The following is a description of a gene set: Any process that modulates the frequency, rate or extent of leukocyte proliferation. Mouse Gene Set: GOBP_REGULATION_OF_LEUKOCYTE_PROLIFERATION species: Mus musculus, and this is the list of marker genes: Il6, Il13, Cd40, Il12rb1, Sash3, Cd320, Nr5a2, Cd244a, H2-DMb1, Ido1, Cdkn2a, Il6st, Pawr, Wnt3a, Ighd, Prnp, Laptm5, Ephb2, Zc3h12d, Igfbp2, Vsig4, Cd209d, Mapk8ip1, Hes1, Csf2, Adk, Ikzf3, Tnfrsf21, Il1a, Rc3h1, Il23a, H2-DMb2, Mif, Cd24a, Tnfsf13, Stat6, Slc4a1, Ahr, Sos1, Bcl6, Cd38 (NCBI Gene Id 12494), Cdkn1a, Tmem131l, Tlr4, Cd80 (CD80 antigen), Csf2rb2, Cd22, H2-Aa (histocompatibility 2, class II antigen A, alpha), Casp3, Rac2, Tspan32, Irf1, Cd74, Tnfsf18, Dhps, Siglecg, Il34, Mef2c, Irgm1, Ccl5, Tnfrsf4, Btnl2, Slfn1, Nck2, Irs2, Prkar1a, Marchf7, Myd88, Vtcn1, Tyk2, Ctnnb1, Vav3, Nmb, Btla, Glmn, Zp3, Pla2g5, Tarm1, Syk, Crp (NCBI Gene Id 98289), Il7, Il5, Il15 (NCBI Gene Id 16168), Icosl, Lilrb4a, Sh3rf1, Grem1, Ripor2, Carmil2, Peli1, Mapk3, Tnfsf13b, Znhit1, Tgfb1, Lyn, Crtam, Tlr9 (NCBI Gene Id 81897), Pkn1, Tac1, Slamf1, Nck1 (NCBI Gene Id 319390), Pycard, Stat5b, Cebpb, Ripk3, St6gal1, Zfp335, Cd37 (NCBI Gene Id 12493), Tirap, Ihh, Atm, Cd4, Itch, Nf1, Gstp1, Sftpd, Cd81, Cd40lg, Ceacam1, Pde5a, Il33, Tnfrsf13b, Bst1, Cd209a (CD209a antigen), Lmo1, Cd274, Erbb2, Csf1, Il20rb, Cd44, Ptprc, Ccr2, Spta1, Pla2g2f, Btk (Bruton agammaglobulinemia tyrosine kinase), Tnfrsf14, Nfatc2, Gpnmb, Il2ra, Cd55b, Lgals3 (lectin, galactose binding, soluble 3), Cd209c, Gal, Scgb1a1, Zap70, Nmbr (NCBI Gene Id 69412), Cd86 (NCBI Gene Id 677252), Itgal, Il21, Csf2ra, Sdc4, Bcl2l1, Csf1r, Tnfrsf9, Ccr7, Gpr183, Igf1, Cd28, Ticam1, Anxa1, Vsir, Twsg1, Il27 (interleukin 27), Pth, Gnrh1, Kitl, Arg1, Pnp, Ndfip1, Gsk3b, Il18 (NCBI Gene Id 16173), Ifng, Btn2a2 (butyrophilin, subfamily 2, member A2), Havcr2, Kit, Selenok, Ocstamp, Cnn2, Il2, Clec4g, Rps3, Tfrc, Flt3l, Blm (NCBI Gene Id 12144), Il3, Phf7, Prlr, Ager, Lilrb4b, H2-T23, Dlg1, Fcgr2b, Scrib, Zbtb7b, Spn, Ccl19, Tsc2, Clcf1, Il12b, Fgf10, Cd59b (CD59b antigen), Chrnb2, Vcam1, Mzb1, Jak3, Ccl12, Ripk2, Il4, Bcl2, Lrrc32, Shh, Prkcq, Dnaja3, Tgfbr2, Dlg5, Tnfsf4 (NCBI Gene Id 226545), Pla2g2a, Bmp4, Nckap1l, Hmgb1, Tcf3, Ppp3ca, Bmi1 (NCBI Gene Id 12151), Fadd (Fas associated via death domain), Il10, Tnfsf9, Cd55, Lst1, Foxj1, Pla2g2d, Cd3e, Ada (NCBI Gene Id 11486), Ighm, Cd1d1, Hhex, Mad1l1, Tnfrsf13c, Slc7a1, Cblb, Ptpn22, Enpp3 (NCBI Gene Id 432441), Ptpn6, Clec2i, Arg2, H2-M3, Il4i1, Tnfrsf1b, Gpam, Sos2, Cd1d2, Il1b, Cd6, Lgals9, Pten, Csf2rb, Bid, Lep, Ptk2, Sox11, Il12a, Rassf5, Slc4a2, Cd46, Ccdc88b, Cd59a, Mpl (NCBI Gene Id 17480), Igf2 (NCBI Gene Id 16002), Slc39a10, Traf6, Atad5, Stat5a, Foxp3, Cd276, Ctla4, Epo, Rasal3 (NCBI Gene Id 320484), Efnb1, Xcl1, Jak2, Coro1a (NCBI Gene Id 16902), Mapk1, Cd300a, Aif1, Cd209e, Tacr1, Pdcd1lg2, Inpp5d, Card11, Tyrobp